The following is a description of a gene set: mouse primary BMDCs were stimulated with tlr ligands and gene expression changes were profiled on Affymetrix arrays species: Homo sapiens Genes up-regulated in comparison of dendritic cells (DC) stimulated with LPS (TLR4 agonist) at 6 h versus DC cells stimulated with Pam3Csk4 (TLR1/2 agonist) at 6 h. from publication Amit I, Garber M, Chevrier N, Leite AP, Donner Y, Eisenhaure T, Guttman M, Grenier JK, Li W, Zuk O, Schubert LA, Birditt B, Shay T, Goren A, Zhang X, Smith Z, Deering R, McDonald RC, Cabili M, Bernstein BE, Rinn JL, Meissner A, Root DE, Hacohen N, Regev A (PMID 19729616) Human Gene Set: GSE17721_LPS_VS_PAM3CSK4_6H_BMDC_UP, and this is the list of marker genes: ECE2, DUSP10, RAD21, UBXN2B, NMNAT1, TLE4, FBXL8 (NCBI Gene Id 55336), HSPA1B, HPCA, MLXIPL, SMARCE1, BAIAP2, PARP4 (poly(ADP-ribose) polymerase family member 4), PIM1, ARHGAP8, CAMK4, FLT3LG, IL12A, RBM17, ACADL, ATG4D, GATAD2A, TCAF2, TBC1D15, IL2RA, KLF4, TAX1BP1, DOK1, MTF1, STK4, HLA-DOA, SLC25A28, MYD88, KARS1, VPS37C, UBE2R2, NTS, PCBD1, IER5, DNAJB11, CHAF1B, CPTP, CISH, BMI1, LCK, PLEKHN1, PEX13, ATP6V1D, KCNMA1, PAK1, NR3C1, FOXRED1, SGK3, ACTRT1, TOX4, ARL10, PHF20L1, WDFY1, SERTAD3, MGP (NCBI Gene Id 4256), CDK5R2, SORL1, GTPBP2, HINT3, NFKBIB, TMEM9, PPIF, CNTRL, LLGL1, RAB25, NAPSA, PSMG4, FSTL3, MACROH2A1, GPSM2, TIFA, IFITM3, SEC24B (SEC24 homolog B, COPII coat complex component), NOTCH2, NID1, ABCG2, TMEM128, BCO2 (NCBI Gene Id 83875), UBE2D1, TBC1D1, DDHD1, ARHGAP6, SEC23IP, RNF14, TMOD3, ZNHIT1, STK3, TMEM70, MEP1A, TMEM209, DGKA, MCM10, ZUP1, TSPO, CDHR1 (NCBI Gene Id 94000), PPP2R2A, SFT2D2, IRF2, HIVEP1, NNMT, ANKS1A, SUZ12, RNF114, PHIP, ARL4A (ADP ribosylation factor like GTPase 4A), PLCL2, PMVK, SLC38A3, SERPINB9, ANAPC5, EEF2K, ST3GAL1, ITGA4, NXF1, SPSB1, CASP1 (caspase 1), RAP1B, COPZ1, RABEPK, FGD6, MFAP5, TRIOBP, C8orf33, SLC5A3, GNPDA2, C1QL1, DOCK8, TNFRSF13C, CRB1 (NCBI Gene Id 6107), TAP2, TLR8, TIMP1, UNC50, KITLG, RSRC2, AAR2 (NCBI Gene Id 51609), ZBTB45, GABRE, EVL, APOBEC1, IL36A, RTP4, RNF19B, C19orf25, PKP4, SESN3 (sestrin 3), ACOT9, BLNK, NOC4L, KHDRBS1, ATAD1, RYBP, FBXO25, PRDX2, DTX1, INSIG2, TIMP2, PTPN22, RANBP1, MED28, GRID2, HK1, CACUL1, CRBN (cereblon), ALOX15, CCDC86, ARF5, TSPYL1, TREM2, USP15, RDX, IFI27L2, PDE7B, CUTC, SEPTIN10 (septin 10), SFXN2 (NCBI Gene Id 94082), INTS9, TNFSF4, DIO1, SLFN12L (NCBI Gene Id 342615), ASPA, PITPNC1, EPC1, NDRG1 (NCBI Gene Id 7998), ARHGAP17, MEF2C, MRPL13, FBXW11, TAF1B (TATA-box binding protein associated factor, RNA polymerase I subunit B), ZBTB7A, SLC40A1, TRPV6, ZFR2, NCOA1